Given this list of marker genes BDNF, CAMKK2, NCAM1, PRL, PRKCA, DIO2, RPS6KA1, NRXN2, HNRNPL, CAMK2A, CAMK4, BCL2, MAPK1, CCND2 (NCBI Gene Id 894), PPARGC1A, NRXN3, SYT2, CREB1 (NCBI Gene Id 1385), MAPK14, CALM1 (NCBI Gene Id 801), RPS6KA5, NGF, DRD1, NRXN1, CAMKK1, CAMK2B, SYT12 (synaptotagmin 12), here is a description of the gene set: Hippocampal synaptogenesis and neurogenesis Human Gene Set: WP_HIPPOCAMPAL_SYNAPTOGENESIS_AND_NEUROGENESIS studied in species Homo sapiens